Given this list of marker genes LARGE2, UGT1A8, CSGALNACT2, POMT2, B4GALT7, UGT1A10, ALG9, EXTL1, DPM1, PYGB, PLOD1 (procollagen-lysine,2-oxoglutarate 5-dioxygenase 1), COLGALT2, B3GNT6, B3GNT4, ALG1L2, GALNT18, GALNT17, MGAT3, UGT8, GALNT3, UGT1A7, LARGE1, B3GALT2, RPN1, AGL, UGT2B10, CHPF2 (NCBI Gene Id 54480), A4GNT, FUT3, MGAT4A, POFUT2, ALG1, PIGP, B3GNT2, A4GALT, EXTL3, ALG12, UGT2B4, HEXA, FUT7, POGLUT3, GALNT16, MGAT5B, GBE1, C1GALT1C1L, GALNT13, GALNT12, GBGT1, UGT2B11, GTDC1, UGT2B28, ALG2, COLGALT1, GYS1, POMT1, GALNT2, OGT, B3GNTL1, GALNTL6, FUT6, PIGM, B4GALNT3, PIGB, B4GAT1, GYG2, B4GALT6, UGT2A1, B4GALT3, GYG1, DPY19L2, A3GALT2, C1GALT1C1, FUT8, GALNT6, GYS2, MTAP, TMTC1, GALNT5, UGT3A2, B3GALT9, UGT3A1, CSGALNACT1, B4GALT1, FUT9, GALNT4, GCNT2 (NCBI Gene Id 880), FUT2, CHPF, FUT4, DPY19L1, ALG10, MGAT4C, GBA1, PIGQ, MGAT5, STT3A, GLT6D1, LALBA, EPM2A, HAS1, EXTL2, ALG11, B3GNT8 (UDP-GlcNAc:betaGal beta-1,3-N-acetylglucosaminyltransferase 8), B3GNT3, UGT2B17, DPY19L2P2, GCNT1, UGT1A1, POFUT1, ALG8, GALNT8, GALNT15, OSTC, B4GALT4, B3GALNT1, GALNT10, ALG6, EXT1, ALG13, UGT2A2, B3GNT5, FUT5, B3GALT5, B4GALT5, ALG3, B4GALNT4, TMTC4, GALNT14, UGT1A9, POGLUT1 (NCBI Gene Id 56983), GCNT4, ALG10B, B3GAT2, PLOD3, PIGZ, UGT1A6, ALG5, GALNT7, RPN2, B4GALNT1, FUT10, HAS3, TMEM260, B3GAT1, B3GNT9, STT3B, UGT2B7, DPY19L4, GBA2, GCNT3, GALNT9, CERCAM, C1GALT1, B4GALT2, RFNG, UGT1A3, GALNT11, FUT1, MGAT4D, EOGT, PIGA, B3GALT1 (beta-1,3-galactosyltransferase 1), TMTC3, PYGM, MFNG, POMGNT2, FUT11, EXT2, PIGV, TYMP, CHSY1, DPY19L3, B3GALT6, LFNG, B3GAT3 (beta-1,3-glucuronyltransferase 3), B3GNT7, B3GLCT, MGAT2, HEXB, UGT1A5, B3GALNT2, UGGT2, ABO, PLOD2, PYGL, MGAT4B, UGCG, UGT2B15, UGT1A4, POGLUT2, B4GALNT2, POMGNT1, B3GALT4, PIGY, HAS2, TMTC2, CHSY3, GCNT7, GALNT1, MGAT1, UGGT1, UGT2A3, here is a description of the gene set: Human Gene Set: GOMF_HEXOSYLTRANSFERASE_ACTIVITY Catalysis of the transfer of a hexosyl group from one compound (donor) to another (acceptor). species: Homo sapiens